Given this list of marker genes Nup153, Eny2, Nup35, Cetn2, Mad1l1, Nup98 (NCBI Gene Id 330609), Mcm3ap, Cetn3, Pcid2, Zc3hc1, Mad2l1, Ranbp2, Tpr, here is a description of the gene set: A filamentous, cage-like assembly on the nuclear face of the nuclear pore complex (NPC). In S. cerevisiae, Mlp1p and Mlp2p are two major components of the NPC nuclear basket. In vertebrates, Tpr is a major component. Mouse Gene Set: GOCC_NUCLEAR_PORE_NUCLEAR_BASKET studied in species Mus musculus